The following is a description of a gene set: studied in species Mus musculus Binding to G-rich, single-stranded, telomere-associated DNA. Mouse Gene Set: GOMF_G_RICH_STRAND_TELOMERIC_DNA_BINDING, and this is the list of marker genes: Terf1, Ctc1, Hnrnpa2b1, Pot1b, Nabp2, Rpa1, Pot1a, Terf2ip, Hnrnpa1, Terf2, Rpa2